Given this list of marker genes Ctnnb1, Six1, Shh, Hdac1, Hdac2, Six4, Wnt10b, here is a description of the gene set: The progression of the fungiform papilla over time, from its formation to the mature structure. The fungiform papilla is a mushroom-shaped papilla of the tongue. species: Mus musculus Mouse Gene Set: GOBP_FUNGIFORM_PAPILLA_DEVELOPMENT